Given this list of marker genes Cfap54, Tpgs1, Armc2, Catsper2, Ropn1, Nsun7 (NCBI Gene Id 70918), Dnah5, Rgn, Defb37, Ccdc40, Enkur, Iqcf1, Cfap45, Pgk2, Or4m1, Cimip2a, Wt1, Cabs1, Cfap44, Cfap95, Tac4, Ift88, Pdcl2, Pacrg, Adam3, Ccr6, Armc3, Cimap1a, Nme8, Dnhd1 (NCBI Gene Id 77505), Cfap47, Ldhc, Catsperz, Tacr2, Slc9b1, Drc1, Cfap251, Spaca9, Cfap210, Saxo4, Cfap52, Cacna1e, Bbs4 (Bardet-Biedl syndrome 4), Garin5a, Misfa, Dnah8, Met, Ttll1, Dnah7c, Lztfl1, AU040320, Cep78, Tektl1, Clxn, Tekt5, Spag8, Efhb, Catsperd, Cfap53, Poc1b, Cimip2c, Vps13a, Cfap206, Slc22a16, Tuba1a, Tekt2 (tektin 2), Spmip6, Spag6, Iqcn, Neurl1a, Cfap65, Tubb4b, Slirp, Tacr3, Tcte1, Mns1, Meig1, Gk2, Prm3, Wfdc6a, Ube2b, Anxa5, Tekt1, Hoatz, Dnah7b, Tekt4, Ccdc146, Tac2, Ccdc65, Taf7l, Tppp2, Insl6, Dpcd, Ccnyl1, Catsper3, Odad3, Defb1, Tex101, Ccdc38, Slc9c1, Ribc1, Ift46, Spem1, Dnah7a, Iqub, Tekt3, Drc7, Dusp21, Dnah3, Wfdc6b, Tmf1, Septin4, Eppin, Smcp, Cfap70, Zmynd12, Celf3, Nme5, Ribc2, Yif1b, Tnp2, Atp2b4, Rsph14, Ccdc159, Ddx4, Spata33, Cfap161, Prss55, Spag6l, Cfap43 (NCBI Gene Id 74924), Atp1a4, Cfap57, Ift81, Dnaaf11, Cfap141, Tmem232, Cfap157, Nme7, Spem3, Dnaaf2, Ttc21a, Ly6k, Ttll5, Tbc1d21, Bbof1, Pierce2, Dnah11, Akap4, Akap3, Cfap90, Rabl2, Garin5b, Cep128, Cimip2b, Ttll6, Spinkl, Ttc12 (NCBI Gene Id 235330), Dnai1, Rfx3, Efcab9, Dnajb13, Ttll8, Cfap97d1, Qrich2 (glutamine rich 2), Pldi (polymorphic derived intron containing), Garin3, Irgc, Slc9b2, Mkks, Spmip8, Slc22a14, Dnai3, Ttll9, Pltp, Txndc2, Mst1, Pla2g3, Apob, Cfap221, Dnaaf6, Cfap58, Lrrc46, C2cd6, Adam7, Dnaaf6rt, Vdac3, Dnah1, Cfap68, Dusp3, Ints13, Cfap126 (cilia and flagella associated protein 126), Bbs1 (NCBI Gene Id 52028), Ash1l, Catsper4, Rnase10, Gas8, Catspere2, Ropn1l, Dnah9, Rsph6a, Efhc2 (NCBI Gene Id 74405), Iqcg, Rnase9, Eno4, Cfap107, Klc3, Pfn4, Spmip9, Tnp1, Cfap61, Tektip1, Dync2h1, Ing2, Rsph1, Dnali1, Gapdhs (NCBI Gene Id 14447), Tssk4, Nphp4, Cfap119, Ccdc39, Tac1, Cfap20, Cfap69, Rhox5, Spmip5, Armc12, Cfap144, Efhc1, Dnah6, Gas2l2, Rsph9, Garin2, Dydc1, H1f6, Kif9, Spef2, Catsper1, Rsph4a, Cfap276, Pierce1, Prdm14, Chrna7, Dnah12, Fsip2, Ttll3, Bbs2, Rsph3b, Dnah17, Dnah14, Dzip1, Dnah2, Inpp5b, Tssk6, Catspere1, Adcy3, Cabcoco1, Spmip10, Sord, Lrrc23, Spag16, Cep131, Efcab6, Dnah10, Dnaja1, Tacr1, here is a description of the gene set: Cell motility due to movement of eukaryotic cilia or bacterial-type flagella or archaeal-type flagella. Mouse Gene Set: GOBP_CILIUM_OR_FLAGELLUM_DEPENDENT_CELL_MOTILITY studied in species Mus musculus